The following is a description of a gene set: Human Gene Set: REACTOME_TBC_RABGAPS TBC/RABGAPs studied in species Homo sapiens, and this is the list of marker genes: ARF6, GGA1, TBC1D25, RABEP1, TBC1D7, RAB5A, TBC1D10C, RAB4A, GGA2, RABGEF1, TSC2, TSC1, SYTL1, RAB33A, OPTN, MAP1LC3B, TBC1D14, TBC1D20, GABARAPL2, TBC1D2, GABARAP, RAB8A, RABGAP1, RAB5C, RAB35, TBC1D10B, GGA3, RAB6B, RAB8B (RAB8B, member RAS oncogene family), RAB5B, TBC1D13, TBC1D17, TBC1D10A, RAB7A, TBC1D15, TBC1D3, TBC1D24 (TBC1 domain family member 24), RAB11B, RAB33B, ULK1, RAB7B, RAB6A, RAB11A, TBC1D16